Given this list of marker genes RRM1, RAB8A, WDR13, TACC3, CENPU, CEP20, TPGS2, ODF2L, FAM184A, AGTPBP1, OCRL, CEP162, TAF1D, CCDC61, NAA40, CDC42BPG (NCBI Gene Id 57006), EXOC7 (exocyst complex component 7), TTC8, PTPN20, AK5, CCDC13, TMEM63A, MDM2, KRT18 (NCBI Gene Id 3875), GNAI3, TRAPPC14, CSTPP1, FLOT1, GPR174, GNAI1, PIK3R5, PCM1, SNTB2, KEAP1, CEP72, KIF5B, CYTH4, MDM1, DBH, MIB1, RPP25, OFD1, BBS2, UPF3B, FLII, DDHD2, PIBF1, TAP1, SKA1, BBS1, TPGS1, CFAP53, PODXL, BBS5, RAB11FIP3, ITGB1BP1, CCDC66, KIAA0753, SPAG9, ZMYND10, RASSF7, CCDC112 (coiled-coil domain containing 112), PJA2, KLHL12, MPP1, SDCCAG8, YTHDF2, CSPP1, FRMD8, CCDC57, LATS2, PBOV1, RAB11FIP5, CEP131, MID1, DZIP1, LRRC49, IFT88, CNTRL, HARBI1, CCDC15, CEP68, WDR90, CLTC, PAX2, CEP57, IL4R, TRAT1, PACSIN2, TEX9, PRKCQ, SPAG5, NEK1, PDIA6, KLHL4, KATNIP, GPRC5C, BRAF, CCDC14, LRIF1, CHD3, C2CD3, CD86, UBN1, MYOF (myoferlin), CEP63, PARD6A, ZBED6, WDR62, PATJ, NR0B1, NEK6, TBC1D31 (NCBI Gene Id 93594), G6PD, ASAP1, HOOK3, SSX2IP, IFT43, C2CD5, PDZD2, FNIP2, NLRC3, BBS7, SLC1A5, CEP290, PXK, CYLD, LHCGR, WRAP73 (NCBI Gene Id 55648), RBM39, BBS4, CD2AP, CFAP263, DYSF, CCDC18, CCNO, NCAPD2, BBS9, NUDT21, PCNT (pericentrin), RABL6, ALDOB, PLK1, KNSTRN, MCRS1, PTPN23 (protein tyrosine phosphatase non-receptor type 23), here is a description of the gene set: A small (70-100 nm) cytoplasmic granule that contains a number of centrosomal proteins; centriolar satellites traffic toward microtubule minus ends and are enriched near the centrosome. Human Gene Set: GOCC_CENTRIOLAR_SATELLITE species: Homo sapiens